The following is a description of a gene set: Human Gene Set: MIR23A_5P from publication Chen Y, Wang X (PMID 31504780) studied in species Homo sapiens Genes predicted to be targets of miRBase v22 microRNA hsa-miR-23a-5p in miRDB v6.0 with MirTarget v4 prediction scores > 80 (high confidence targets)., and this is the list of marker genes: CYRIA, TEC, LIPG, ZMYM3, KCNIP1, CHD4, REG1A, GOLGA6L1, BARX2, KCNC4, ABCA1, PRR23E, GIPC3, MAPRE1, TMEM217, IGF2, APRG1, PPA2, CCNJL, USH2A, GPC6, ERC2, VSIG1, CAMK1D, ATXN1, MTMR4, HIRIP3, SSMEM1 (NCBI Gene Id 136263), NTRK3, FOXC1, GOLGA6L6, MLIP, CCDC97, TMEM140, DSC1, TMEM127, MYEOV